The following is a description of a gene set: Human Gene Set: GOBP_MEIOTIC_CELL_CYCLE_PHASE_TRANSITION The cell cycle process by which a cell commits to entering the next meiotic cell cycle phase. studied in species Homo sapiens, and this is the list of marker genes: CDC25B, NDC80, ZWINT, PKMYT1, KNL1, MAPK15, PDIK1L (PDLIM1 interacting kinase 1 like), MOS, CHFR, USP17L2, CCNB2, STK35, TTK, CDC20, OVOL1, CDC25A, CDC25C